Given this list of marker genes ILK, PXN, ITGB1, PARVA, here is a description of the gene set: part of: Cell-extracellular matrix interactions Reactome Pathway: Localization of the PINCH-ILK-PARVIN complex to focal adhesions The interactions among ILK, PINCH, and parvins are necessary but not sufficient for localization of ILK to cell-ECM adhesions. Additional proteins that interact with PINCH-ILK-parvin complex components likely participate in mediating its localization. species: Homo sapiens